Given this list of marker genes C8G, STRA6, CRABP1, RBP1, RBP2, LRAT, ADH7, RBP3, ADH4, CYP2W1, RBP7, RLBP1, CRABP2, RBP5, RBP4, CYP27C1, here is a description of the gene set: species: Homo sapiens Binding to retinol, vitamin A1, 2,6,6-trimethyl-1-(9'-hydroxy-3',7'-dimethylnona-1',3',5',7'-tetraenyl)cyclohex-1-ene, one of the three components that makes up vitamin A. Retinol is an intermediate in the vision cycle and it also plays a role in growth and differentiation. Human Gene Set: GOMF_RETINOL_BINDING